The following is a description of a gene set: from publication Hill JA, Hall JA, Sun CM, Cai Q, Ghyselinck N, Chambon P, Belkaid Y, Mathis D, Benoist C (PMID 19006694) Genes down-regulated in comparison of conventional T cells treated with retinoic acid (tretinoin) versus untreated conventional T cells. species: Homo sapiens Human Gene Set: GSE13306_RA_VS_UNTREATED_TCONV_DN CD4(+)Foxp3(+) regulatory T (Treg) cells originate primarily from thymic differentiation, but conversion of mature T lymphocytes to Foxp3 positivity can be elicited by several means, including in vitro activation in the presence of TGF-beta. Retinoic acid (RA) increases TGF-beta-induced expression of Foxp3, through unknown molecular mechanisms. We showed here that, rather than enhancing TGF-beta signaling directly in naive CD4(+) T cells, RA negatively regulated an accompanying population of CD4(+) T cells with a CD44(hi) memory and effector phenotype. These memory cells actively inhibited the TGF-beta-induced conversion of naive CD4(+) T cells through the synthesis of a set of cytokines (IL-4, IL-21, IFN-gamma) whose expression was coordinately curtailed by RA. This indirect effect was evident in vivo and required the expression of the RA receptor alpha. Thus, cytokine-producing CD44(hi) cells actively restrain TGF-beta-mediated Foxp3 expression in naive T cells, and this balance can be shifted or fine-tuned by RA., and this is the list of marker genes: ADAM12, DNAJC19, DLEU7, OR8A1, ARHGEF38, DAP, DMRTA1, TRIT1, KPLCE, ENSA, SLC25A44, SAXO5, SHISA4, AIPL1, MAP1B, ADAM32, RCOR2, OTOP3, TFAP2A, RNASE2, UBD, GFI1B, GTF2F2, SYT16, BMP1, CDC5L, MMP10, EXD1, ZC2HC1A, RAB35, MSX1, FGF18, UTP3, RNF125, NPR1 (natriuretic peptide receptor 1), CD47, PRPS1, KLRG2, WWP1, RALGAPA2, AXIN2, IQCF5, CCL25, C15orf48 (chromosome 15 open reading frame 48), EFTUD2, IL5RA, IPMK, PAOX, KCNJ15, CHADL, LITAF, ALDH5A1, PIGF, RBM4B, IFITM3, LRRTM1, P3H2, EXOC3L4, MYT1L, C8orf34, CDH3, NDUFAF5 (NCBI Gene Id 79133), B4GALT6, MME, PCDHB16, GJD2, EBF2, SPRN, TRDN, CENPF, BTBD10, LTK, CLASP2, PYM1, MATCAP2, SLC11A2, BEX3, DNAH6, PAG1, C4orf17, B2M, TULP3, BUD13, RCAN2, FAM204A, BOLA2, ABHD16B, VSTM4, LRRC3, MAD2L1, PROZ, VSIG4, IFITM2, UXS1, POSTN, GTSF1, NR1I2, GRAP2, SLC16A5, CPLANE2, LYPD2, PLD4, PKP4, FTH1, APH1B, KCNS3, UBE2K, TRIM60, FZD4, ANKS4B (NCBI Gene Id 257629), GPR155, SPINK5, ODC1, ADD3, CXCR6, KCTD20, CS, PANK2, DNM3, DCAF10, DLX3, FUNDC2, MS4A8, ENTPD1, PKN2, PAK1IP1, RAB38, CLDN15, NAA80, VSX1, OAS3, FPR1, IL18R1, ADIG, GRIN3B, DNASE2, RLIM, ADH4 (NCBI Gene Id 127), PTPRM (protein tyrosine phosphatase receptor type M), CHCHD7, IL10RA, LYPD5, DCK, P2RY13, CCR2, PSMA6, TAF4B (NCBI Gene Id 6875), MMUT, PROKR2, CDKL2, TIFAB, ACBD3, RAMAC, INCENP, RYR1, COMMD1, PARP12, CCDC175, ZNF462, SPAG8, CRB3, TRARG1, SCP2D1, FAM83F, SERPING1, SLC25A6, CIMIP6, TMEM106A, DNAAF10, CFAP65, MTRF1L, TTLL7, F2RL1, CRISPLD1, CHMP2A, SEMA3G, ABLIM3, ACP3, ZDHHC2, FGFR3, BST2, TEX47, NPY1R, BEST2, TMEM132A, CYB561, ADORA2A, HSPB8, ADGRL2, MYO1F, FAM163B, SLC25A2, ADORA3, NOS1AP, ENPP3, SEZ6L, EIF4E3, EHD1, PDGFD, MDH1